Given this list of marker genes SYK, HTR1A, SLC18A2, CRH, FCER1G, P2RX1, LILRB1, SLC6A4, HTR1B, here is a description of the gene set: species: Homo sapiens Human Gene Set: GOBP_SEROTONIN_SECRETION The regulated release of serotonin by a cell. Serotonin (5-hydroxytryptamine, or 5-HT) is a monoamine synthesized in serotonergic neurons in the central nervous system, enterochromaffin cells in the gastrointestinal tract and some immune system cells.